Given this list of marker genes CENPN, GSE1, PSMD14, SPAG5, BAALC, CARTPT, RNASE9, CEP55, MLLT1, TIMELESS, AQP5, MTFR2, SOX11, CSAG2, RACGAP1, KIF20A, RNFT2, HSPA14, CDCA8, BUB1 (BUB1 mitotic checkpoint serine/threonine kinase), SEMA4C, EBP, SCLT1, POLD1, DSCC1, SMARCA4, FADD, TRIM24, PDX1, ASPM, PSMD2, SHMT2, PRAME, FA2H, TNNC2, UBE2T, CTPS1, MYBL2, UHRF1, IL20RB, TMEM208, PMCH (pro-melanin concentrating hormone), MELK, CDCA5, RASIP1, EXO1, ATP2C2, KLRG2, AMH, PTTG1, NDC80, here is a description of the gene set: species: Homo sapiens from publication Naderi A, Teschendorff AE, Barbosa-Morais NL, Pinder SE, Green AR, Powe DG, Robertson JF, Aparicio S, Ellis IO, Brenton JD, Caldas C (PMID 16936776) Up-regulated genes in the breast cancer prognostic signature of genes that significantly correlated with survival. Prognostic signatures in breast cancer derived from microarray expression profiling have been reported by two independent groups. These signatures, however, have not been validated in external studies, making clinical application problematic. We performed microarray expression profiling of 135 early-stage tumors, from a cohort representative of the demographics of breast cancer. Using a recently proposed semisupervised method, we identified a prognostic signature of genes that significantly correlated with survival (hazard ratio (HR): 5.97, 95% confidence interval: 3.0-11.9, P = 2.7e-07). In multivariate analysis, the signature performed independently of other standard prognostic classifiers such as the Nottingham Prognostic Index and the 'Adjuvant!' software. Using two different prognostic classification schemes and measures, nearest centroid (HR) and risk ordering (D-index), the 70-gene classifier was also found to be prognostic in two independent external data sets. Overall, the 70-gene set was prognostic in our study and the two external studies which collectively include 715 patients. In contrast, we found that the two previously described prognostic gene sets performed less optimally in external validation. Finally, a common prognostic module of genes that associated with survival in both our cohort and the two external data sets was identified. In spite of these results, further studies that profile larger cohorts using a single microarray platform, will be needed before prospective clinical use of molecular classifiers can be contemplated. Human Gene Set: NADERI_BREAST_CANCER_PROGNOSIS_UP